The following is a description of a gene set: species: Homo sapiens from publication Gavish A, Tyler M, Greenwald AC, Hoefflin R, Simkin D, Tschernichovsky R, Galili Darnell N, Somech E, Barbolin C, Antman T, Kovarsky D, Barrett T, Gonzalez Castro LN, Halder D, Chanoch-Myers R, Laffy J, Mints M, Wider A, Tal R, Spitzer A, Hara T, Raitses-Gurevich M, Stossel C, Golan T, Tirosh A, Suvà ML, Puram SV, Tirosh I (PMID 37258682) In this study, an extensive analysis was conducted to define meta-programs (MPs) capturing intra-tumor heterogeneity across a spectrum of tumor types. The approach utilized non-negative matrix factorization (NMF) to analyze each cell type separately within individual tumor samples. This involved the analysis of malignant cells, macrophages, fibroblasts, endothelial cells, epithelial cells, T-cells, and B-cells. NMF was executed with varying parameter values (K=4, 5, 6, 7, 8, 9), thereby generating 39 programs for each cell type per sample. Each NMF program was summarized by the top genes based on NMF coefficients.\nRobust MPs were then delineated for each cell type using a set of stringent criteria, including recurrence within the same tumor, similarity to programs in other tumors, and non-redundancy within a tumor. Subsequently, these robust NMF programs were clustered (per cell type) based on Jaccard similarity, leading to the identification of MPs associated with each cell type.\nTo enhance the quality of the MPs, a refinement steps were undertaken, involving the removal of MPs suspected of reflecting low-quality data (with an overrepresentation of ribosomal proteins or mitochondrial-encoded genes), single-study inclusion, or similarity to miss-annotated cell types. Genes upregulated in subsets of cells of a given type within various tumors Human Gene Set: GAVISH_3CA_MALIGNANT_METAPROGRAM_14_EMT_3, and this is the list of marker genes: S100A6, S100A10, RHOC, KRT18, VIM, CRIP1 (cysteine rich protein 1), S100A14, FXYD3, KRT7, LGALS1, CKB, LMNA, LGALS3, PLP2, TNFRSF12A, S100A4, S100A16, IFI27 (interferon alpha inducible protein 27), KRT8 (keratin 8), CLIC1, IL32, TMSB4X, MYADM, MYL12A, KLF6, KRT19, STMN1, TUBA1A, EMP3, CD24, ANXA1, C19orf33, CLDN4, S100P, HSPB1, TAGLN2, S100A11, MMP7, EMP1, SH3BGRL3, TM4SF1, RAB11FIP1, PHLDA2, EZR, FLNA, ISG15, MDK, CRIP2, ANXA3, ANXA2